The following is a description of a gene set: Any process that activates or increases the frequency, rate or extent of signaling pathways initiated by the cross-linking of an antigen receptor on a B cell. Mouse Gene Set: GOBP_POSITIVE_REGULATION_OF_B_CELL_RECEPTOR_SIGNALING_PATHWAY studied in species Mus musculus, and this is the list of marker genes: Cmtm3, Prkch, Slc39a10, Cd81, Stap1, Foxp1, Nfam1